The following is a description of a gene set: Delayed achievement of the ability to roll front to back and back to front. Delayed ability to roll over Human Gene Set: HP_DELAYED_ABILITY_TO_ROLL_OVER studied in species Homo sapiens, and this is the list of marker genes: NDUFA8, LMNA, ACTA1, TAF8, ATP6V0A1, SLC25A12, VRK1, YIF1B, SLC31A1, PGAP1, CELF2, MECP2, ADCY5, MRPS25, SON, VPS35L